Given this list of marker genes ABCA6, ABCA10, ABCA9, ABCD2, ABCA5, ABCA3, ABCD1, ABCD3 (ATP binding cassette subfamily D member 3), ABCG1, PEX3, APOA1, PEX19, ABCA12, ABCA2, ABCA7, ABCG8 (ATP binding cassette subfamily G member 8), ABCG5, ABCG4, here is a description of the gene set: studied in species Homo sapiens ABC transporters in lipid homeostasis Human Gene Set: REACTOME_ABC_TRANSPORTERS_IN_LIPID_HOMEOSTASIS